The following is a description of a gene set: Signaling by BMP species: Homo sapiens Human Gene Set: REACTOME_SIGNALING_BY_BMP, and this is the list of marker genes: FSTL1, SMAD6, GDF2, UBE2D1, SMAD1, ZFYVE16, CER1, BMPR2, SMAD5, SMAD4, SKI, SMURF2, INHBA, TGFBR3, CHRDL1, NOG, BMP10, SMAD7, AMHR2 (anti-Mullerian hormone receptor type 2), ACVRL1, SMAD9, AMH, SMURF1, ACVR2B, INHA, ACVR2A, BMPR1A, UBE2D3, BMP2, BMPR1B, GREM2